Given this list of marker genes Ccl9, Notch1, Bmp4, Cxcl14, Ddit3, Tgfb1, Tbx3, Zfhx3, Ankrd2, Csrp3, Ccl17, Prickle1, Sox9 (SRY (sex determining region Y)-box 9), Il18, Sox4, Nmrk2, Gdf3, Prl2c2, Il36g, Mbnl3, Mkx, Cmtm5, Eid2b, Cxcl10, Dll1, Sra1, Mstn, Ppard, Tnf, Sostdc1 (NCBI Gene Id 66042), Sox8, Id3, Tmem182, here is a description of the gene set: Any process that stops, prevents, or reduces the frequency, rate or extent of myoblast differentiation. A myoblast is a mononucleate cell type that, by fusion with other myoblasts, gives rise to the myotubes that eventually develop into skeletal muscle fibers. studied in species Mus musculus Mouse Gene Set: GOBP_NEGATIVE_REGULATION_OF_MYOBLAST_DIFFERENTIATION